The following is a description of a gene set: Abnormal megakaryocyte morphology studied in species Homo sapiens Any structural anomaly of megakaryocytes. Mature blood platelets are released from the cytoplasm of megakaryocytes, which are bone-marrow resident cells. Human Gene Set: HP_ABNORMAL_MEGAKARYOCYTE_MORPHOLOGY, and this is the list of marker genes: RPS14, JAK2 (Janus kinase 2), GNA14, ZNFX1, SLC7A7, TP53, GALE, TET2, MPL, MYSM1, UBA1, GATA1, GP9, RFWD3, CALR, GNE, GP1BB, HOXA11, GP1BA, SLC35A1, SF3B1, GATA2, SAMD9, KIF15, ANKRD26, SLC30A7, SH2B3, FYB1, MYH9